Given this list of marker genes PRF1, KCNK5, LPIN2, WDR91, BCKDHB, GABARAPL1, DYNLT2B, AUNIP, RBBP5, SMC4, RNASEL, RANBP9, KCTD9, BTF3, CENPU, KLHDC1, GTDC1, ACSL3, FRMD5, TPX2, CCSAP, STS, INSYN1, DMBX1, SLC43A3, TUBE1, IKBIP, TIRAP, CR1L, KLC3, TF, HNRNPA0, IREB2, TMEM52, ZC4H2, LTN1, NR3C2, MKLN1, WTIP, RNASE10, PFDN4, TMEM120A, EML2, ZNF260, C6orf118, SLC27A3, CCDC183, CNRIP1, DNAJC12, ZCCHC18, LRRC4C, SNX21 (sorting nexin family member 21), PSPH, ALKBH3, S100A5, TFAP2D, STK17B, EBF1, NFIC, CNN1, NUP107, CRABP2 (cellular retinoic acid binding protein 2), PIK3AP1, JUND, SPRY2, HECA, TMPO, TEKT4, PDCD10, TMEM168, NSDHL, EMP3, TARS1, HIF1A, RAD17, ANKRD6, LIMD1, BARX2, DYNLT3, UBXN2B, TBK1, TMEM165, CCN4, CARTPT, PSMB10, FBXO3, IGF1, TRIP4, RALA, BAHD1, AADAT, RBL1, SLC2A8, PRPF6, PFKP, GIPC3, CDCA3, MYOF, PDZD8, HSPA2, PTBP3 (NCBI Gene Id 9991), CLIC4, LAMTOR4, DYDC2, NPAS1, KCNG4, HSD17B3 (NCBI Gene Id 3293), NWD2, SH3GL3, PLEKHA2, COG4, MICAL1, MORC2, DERL2, TIA1, MARK3, KIFAP3, RNF135, ENOX2, ZNF768, VEZT, HEPHL1, MAN2A1, FAM241B, IL18RAP, IFIH1, ADPRH, TARS3, NAXE, P2RX2, FAM193B, MARCHF6, KIAA0319, SYPL1, CCDC61, NAB2, RNF145, P2RY10, NFKBIL1, ZFAND1, SLC17A6, POU6F2, PLXND1, F5, TRIM5, JUNB, ZBTB33, HBP1, HSPA4L, LRRC59, SSTR3 (NCBI Gene Id 6753), SF3B2, CENPJ, RAP1A, ABRACL, MANF (mesencephalic astrocyte derived neurotrophic factor), RAB7A, TECPR1, PSMD14, CHORDC1, WRAP73, PKN3, HEBP2, PITPNM1, DAAM1, CBFA2T2, FEZ2, WDR83, CSF2RA, TM2D1, CDH2, MFSD2A, DDHD1, VAMP7, SURF1, RSPH3, SPON2, KIF21B, UBE2U, PNRC1, GSTO1, CARF, CLPX, SRP54, SELENOS, FZR1, GLB1, CNTROB, LSS, B4GALT4, EXOC5, TTLL9, DUOX1, TMOD1, AK5, MARVELD1, LRRK2, PPP1R18, ZNF219, here is a description of the gene set: Human Gene Set: GSE6259_DEC205_POS_DC_VS_CD4_TCELL_UP from publication Dudziak D, Kamphorst AO, Heidkamp GF, Buchholz VR, Trumpfheller C, Yamazaki S, Cheong C, Liu K, Lee HW, Park CG, Steinman RM, Nussenzweig MC (PMID 17204652) Genes up-regulated in splenic DEC205+ dendritic cells versus CD4 T cells. studied in species Homo sapiens Dendritic cells (DCs) process and present self and foreign antigens to induce tolerance or immunity. In vitro models suggest that induction of immunity is controlled by regulating the presentation of antigen, but little is known about how DCs control antigen presentation in vivo. To examine antigen processing and presentation in vivo we specifically targeted antigens to the two major subsets of DCs using chimeric monoclonal antibodies. Unlike CD8+ DCs that express the cell surface protein CD205, CD8- DCs, which are positive for the 33D1 antigen, are specialized for presentation on MHC class II. This difference in antigen processing is intrinsic to the DC subsets and associated with increased expression of proteins associated with MHC processing.